Given this list of marker genes ABCA3, SFTPA1, CSF2RA, SFTPD, SFTPC, SFTA3, SFTPB, CSF2RB, SFTPA2, SLC34A2, here is a description of the gene set: Reactome Pathway: Diseases associated with surfactant metabolism The reactions annotated here describe genetic defects in genes regulating surfactant homeostasis which are associated with severe acute and chronic lung diseases in newborns and older infants. studied in species Homo sapiens part of: Diseases of metabolism